The following is a description of a gene set: from publication Amit I, Garber M, Chevrier N, Leite AP, Donner Y, Eisenhaure T, Guttman M, Grenier JK, Li W, Zuk O, Schubert LA, Birditt B, Shay T, Goren A, Zhang X, Smith Z, Deering R, McDonald RC, Cabili M, Bernstein BE, Rinn JL, Meissner A, Root DE, Hacohen N, Regev A (PMID 19729616) studied in species Homo sapiens mouse primary BMDCs were stimulated with tlr ligands and gene expression changes were profiled on Affymetrix arrays Genes down-regulated in comparison of dendritic cells (DC) stimulated with CpG DNA (TLR9 agonist) at 12 h versus those stimulated with CpG DNA (TLR9 agonist) at 24 h. Human Gene Set: GSE17721_12H_VS_24H_CPG_BMDC_DN, and this is the list of marker genes: SPN, ZNF444, WWC2, RNF38, SLC6A13, PARK7, PTEN, FIGNL1, CSPP1, MRPL47, TMED2, BPNT2, PSMA6, GCLC, PARN (NCBI Gene Id 5073), BORCS5, EHHADH, BEX4, HADH, ZDHHC6, PDGFC, STARD10, KLF7, GNPDA1, SCAF11, XRCC6, UBA2, HACD3, LSM14B, ERMP1, HILPDA, PEX6, RPL36A, CIAO1, RALBP1, ZNF124, PSMA2, ATL2, FKBP4, AGK, PHLDA2, D2HGDH, NDUFAF4, SEMA4B, TUBA4A, CHERP, RBBP7, UBR1, AXIN1, DBR1, UCHL3, GMNN, STMN1, DCTN3, DDB2, DOLK, PPIL4, LRRC57, TM4SF4 (transmembrane 4 L six family member 4), ADH5, DHRS7B, MRPL12, FASTKD2 (FAST kinase domains 2), ABCC3, GUCY1B1 (NCBI Gene Id 2983), C1D, RBM28, LRRTM1, CBFA2T2, IFT70A (intraflagellar transport 70A), LYL1, IRX2, FADS1, STRA8, WDR6, LUZP1, COL5A1, HABP4, LPIN2, DNER, AP2A2, OTULINL, PRKRA, HSD17B10, CYP4F3, ATXN7L1, SOD1, HSP90AB1, RHOG, SIGLEC7, TUBA1A, ELP2, FUCA2 (NCBI Gene Id 83934), ROCK2, PRKAG1, SH3GLB1, GSTM1, TMEM94, NDUFB8, COQ7, RNF167, SERBP1, PAK1IP1, RDH12, GTF3C1, PILRB, PACC1, BCKDHA, MMP9, ERGIC3, PEX2, MAP1LC3B, LIAS, RPA3, MTMR6, LRPPRC, ORM1, MMS19, TM6SF1, MMP2, COX5A, SERPINE1, APEX1, ABCF2 (NCBI Gene Id 11195), LRPAP1, DPH5, C12orf57, CDKN1B, UBXN2B, INPP5D, XPC, MTX2 (metaxin 2), PRDX1, C21orf91, STIP1, CEP85, TGFBR2, NAB1, SPTBN1, GSTT2, PIK3C3, DOCK1, TRAPPC12, POLRMT, RCBTB2, WDFY3, EIF2S1, VPS37A, PEX19, NDUFAB1, TRIAP1, CDK5RAP3, CES1, DGCR2, NDUFA6, PIK3CG, NTPCR, TXNDC12, SNIP1, PCOLCE2, CHCHD3, LOX, ELOVL5, TEPSIN, CASP6, MMUT, MCEE, OSBPL11, CDCP1, NDUFA9, ATP5PO, LAGE3, BCCIP, BCL2L14, MRPS30, STAT6, SEC24D, IFITM2, HTATIP2, ABHD14B, HCCS, CDK2AP2, TXNL4A, TEX10, SMYD5, CLCC1, DNA2, BABAM1, MRPL42, SOX21, NDUFS7, CYB5A, YY1, SLC22A4, UNK, GPAM, PSEN2, MEIS1, NUP58, MSX2